The following is a description of a gene set: studied in species Homo sapiens Human Gene Set: REACTOME_COPI_INDEPENDENT_GOLGI_TO_ER_RETROGRADE_TRAFFIC COPI-independent Golgi-to-ER retrograde traffic, and this is the list of marker genes: RAB6B, ACTR1A, TUBA4A, TUBA1B, TUBB8B, DCTN2 (NCBI Gene Id 1640), TUBA3E, ACTR10, TUBA8, TUBB8, TUBB4B, DYNC1LI2, DYNC1I1, DCTN5, TUBB6, DYNC1H1, PAFAH1B2, DYNLL1, PLA2G6, RAB3GAP1, PAFAH1B1, TUBA1A (NCBI Gene Id 95407), TUBAL3, DCTN6, GALNT2, DYNC1I2, CAPZB, TUBA3C, CAPZA3, TUBA3D, RAB6A, DYNLL2, TUBB2B, DCTN4, TUBB1, BICD2, DYNC1LI1, CAPZA2, PLA2G4A (phospholipase A2 group IVA), RAB3GAP2, GALNT1, AGPAT3, TUBA4B, DCTN3, TUBB2A, BICD1, TUBB4A, DCTN1, CAPZA1, PAFAH1B3, TUBA1C, TUBB3, RAB18